The following is a description of a gene set: species: Homo sapiens Human Gene Set: KEGG_MEDICUS_PATHOGEN_HCMV_US28_TO_GNA12_13_RHO_SIGNALING_PATHWAY Pathway Definition from KEGG: (CCL2,CCL3,CCL4,CCL5,CX3CL1) -> US28 -> GNA12/13 -> (ARHGEF12,ARHGEF1) -> RHOA -> ROCK1/2 -> CTNNB1 HCMV US28 to GNA12/13-Rho signaling pathway. Pathway ID: N00406. Pathway type: Pathogen. Pathway class: nt06167 Human cytomegalovirus (HCMV)., and this is the list of marker genes: ARHGEF12, CCL3, GNA12, CCL2, RHOA, CX3CL1, CCL4, CCL5, ROCK2, CTNNB1, GNA13, ROCK1, ARHGEF1